Given this list of marker genes Mgst2, Ephx2, Cyp4a12a, Ehhadh, Gpx1, Gpx4, Acaa1a, Ptgr2, Cyp4f18, Mgst3, Ptgr1, Alox15, Dpep1, Cyp4a12b, Hpgd, Ggt1, Lta4h, Acox3, Alox12, Cyp4f14, Ltc4s, Acox2, Dpep2, Alox5, Acox1, Ggt5, Cyp4a10, here is a description of the gene set: species: Mus musculus Mouse Gene Set: WP_EICOSANOID_METABOLISM_VIA_LIPOXYGENASES_LOX Eicosanoid metabolism via lipoxygenases (LOX)